The following is a description of a gene set: from publication Agarwal P, Raghavan A, Nandiwada SL, Curtsinger JM, Bohjanen PR, Mueller DL, Mescher MF (PMID 19592655) Genes up-regulated in comparison of unstimulated CD8 T cells at 72 h versus CD8 T cells at 72 h after stimulation with IL12. studied in species Homo sapiens Human Gene Set: GSE15930_STIM_VS_STIM_AND_IL12_72H_CD8_T_CELL_UP Differentiation of naive CD8 T cells into cytotoxic effector cells requires three distinct signals- antigen (signal 1), costimulation -B7-1 (signal 2) and cytokine, either interleukin-12 or interferon-a/b (signal 3). Interaction of naive CD8 T cells with antigen and B7-1 programs cell division and proliferation whereas the presence of cytokines- IL-12 or IFNa/b promote survival, differentiation and memory establishment. In the absence of signal 3, the cells interacting with antigen/B7-1 undergo tolerance induction. The objective of this study was to elucidate the mechanisms how the provision of signal 3 promotes differentiation and averts tolerance induction in CD8 T cells. Trichostatin A is a pharmacological agent that inhibits histone deacetylase activity, hence regulating chromatin structure and gene expression and differentiation in many cell types. Gene signature profiles of IL-12, IFNa/b and trichostatin A stimulated cells were compared to elucidate the molecular mechanisms of gene regulation. Oligonucleotide microarray analysis is carried out to determine the extent and molecular nature of the CD8 T cell differentiation program induced by IL-12 or IFNa/b in concert with antigen and B7-1 signal., and this is the list of marker genes: FZD6, PSMB1, HDAC1, ATG13, IMPA1, TANK, NUTF2, KLF12, C6orf62, TMEM14C, SS18, PMM2, RUNX1T1, TMEM50B, PREB, H3C7, RASGRP2, RBBP4, BRD7, DAB1, RACK1, METTL17, PNLIPRP1, MIF4GD, EIF2B4, CTSC, CLGN, SPATA13, RIPOR2, LRPPRC, RNGTT, PLAU, SPICE1, SRSF9, SON, PTPN18, HOXB7, IGFBP6, ECE1, PTP4A2, ATP5PF, DCAF13, RIOX2 (ribosomal oxygenase 2), IQGAP2, IREB2, KMT2E, ANKRD10, DNAJA1, SERINC3, IKBKB, SPIN1, PLAC9, CALCB, EPHB6, LEPROT, S100PBP, SLC23A2, H2BC18, SRMS, TBC1D23, GRPEL2, SLMAP, PCBD2, TTF1, NDUFB10, IL1RN, TNFRSF1A, HLA-DOB, ANKRD13A, GLMP, GABRB1, POLR2F, FBXW2, CSRP1, CBR1, PSMC1, RUNDC3A (NCBI Gene Id 10900), IVNS1ABP, MCM5 (NCBI Gene Id 4174), PKNOX1, MSH3, FBXO38, INTS8 (NCBI Gene Id 55656), ASF1B, EMC2, IFIT2, CFI, KIF3C, FCER2, SEC23A, CD14, TM9SF2, CREBBP, APBB1IP, KCMF1, FOSB, MEF2D, PRPF39, ATF2, GALK2, ISG15, MTARC2, ABRACL, SYNRG (synergin gamma), UBE2N, GSTT2, TIGD5, HMGB2, SPAST, TXNDC12, COPA, PRSS58, GABPA, IRF7, RPA3, MCUR1, OGFOD2, ATP6AP2, PSTPIP2, SAYSD1, IQGAP3, CNN2, TPT1, ATXN2, CLOCK, MAST2, SUCLA2, AXIN1, COPZ1, ANLN, E2F5, DNAJC9, TYSND1, SEPTIN4, EMC3, MRPS21, KANSL2, BMP15, SYNGR2, CBFA2T3, DEK, CELF1, MPP3, CAPZA2, CACNA1H, NCOA2, DDX39B, CLEC4D, EPS15, GPM6B, EMP3, HNRNPC, RENBP, NUSAP1, MRPS14, MAT2B, IRF2BP1, ATXN7L3, PRPF8, GBA2, BUD31, CHPT1, KAT7, OMD, FRAT1, CRP, RAD52, DMRTB1, RP9, INHBC, PNKP, POLR3K, ROCK1, MFSD14A, NFE2, SLC22A6, NSMCE1, GJC1, ROBO3, ATP5F1A, FRAT2, SIPA1L2, B4GALNT1, FIP1L1, LGALS9B, DIAPH1, UBE2K, CCR6, CLPTM1L, MPHOSPH10, SEPTIN10, SEPHS2, HTR3A, ATXN1 (ataxin 1), THOC7, NEDD8, GPRASP1, SEC11A, TEAD4